The following is a description of a gene set: Steroid hormone receptors regulate gene expression, interacting with target DNA sequences but also activating cytoplasmic signaling pathways. Using the human 11beta-hydroxysteroid dehydrogenase type 2 (11beta-HSD2) gene as a model, we have investigated the contributions of both effects on a human progesterone-responsive promoter in breast cancer cells. Chromatin immunoprecipitation has identified two different mechanisms of hormone-induced progesterone receptor (PR) recruitment to the 11beta-HSD2 promoter: (i) direct PR binding to DNA at the proximal promoter, abrogated when PR contains a mutated DNA binding domain (DBD), and (ii) STAT5A (signal transducer and activator of transcription 5A)-mediated recruitment of PR to an upstream distal region, impaired by AG490, a JAK/STAT pathway inhibitor. The JAK/STAT inhibitor, as well as expression of dominant-negative STAT5A, impairs hormone induction of 11beta-HSD2. On the other hand, the DBD-mutated PR fully supports 11beta-HSD2 expression. These results, along with data from a deletion analysis, indicate that the distal region is crucial for hormone regulation of 11beta-HSD2. We show active RNA polymerase II tracking from the distal region upon PR and STAT5A binding, concomitant with synthesis of noncoding, hormone-dependent RNAs, suggesting that this region works as a hormone-dependent transcriptional enhancer. In conclusion, coordination of PR transcriptional effects and cytoplasmic signaling activation, in particular the JAK/STAT pathway, are critical in regulating progestin-induced endogenous 11beta-HSD2 gene expression in breast cancer cells. This is not unique to this promoter, as AG490 also alters the expression of other progesterone-regulated genes. species: Homo sapiens Genes responding to progestin R5020 treatment of T47D-MTVL cells (breast cancer). Human Gene Set: SUBTIL_PROGESTIN_TARGETS from publication Subtil-Rodríguez A, Millán-Ariño L, Quiles I, Ballaré C, Beato M, Jordan A (PMID 18378698), and this is the list of marker genes: ABCC5, RPS6KA1, CCND1, EGF, JUN (Jun proto-oncogene, AP-1 transcription factor subunit), DUSP1, CCN1, CEBPD, HMGB3, BNIP3 (BCL2 interacting protein 3), HDAC9, BCAR1, KAT2B, BCAS2, H1-10, GRB2, RASL10B, ITGA2, NME2, TP53BP2, TGFA, MAP4K5, GADD45A, SOS1, CDKN1C, IL6ST, DNAH1, BCCIP, UCHL5, SAP30, MAP3K3, ATF3, GM2A, POLR2K (RNA polymerase II, I and III subunit K), ECI2, AR